Given this list of marker genes GTF2I, GTF2IRD1, BAZ1B, DDX6, STRA6, ZMYM2 (NCBI Gene Id 7750), LIMK1, PUF60, NCF1, GTF2IRD2, EIF4H, CLIP2, TMEM270, KMT2D, METTL27, CCNQ, MLXIPL, RAD51, SLX4, MNX1, FKBP6, RTTN, FANCF, VPS37D, DYRK1A, ELN, STX1A, DNAJC30, BUD23, FGFR1, RFC2, WAC, GNB2, ZEB2, TBL2, KDM6A, FANCD2, PALB2, here is a description of the gene set: Human Gene Set: HP_PELVIC_KIDNEY species: Homo sapiens A developmental defect in which a kidney is located in an abnormal anatomic position within the pelvis. Pelvic kidney